Given this list of marker genes Ntn4, Lrp5, Fer, Ndp, Fzd4, here is a description of the gene set: Any process that mediates the transfer of information between the extracellular matrix and a cell. studied in species Mus musculus Mouse Gene Set: GOBP_EXTRACELLULAR_MATRIX_CELL_SIGNALING